Given this list of marker genes AICDA, UNG (uracil DNA glycosylase), POLM, PAXIP1, TNF, TRAF2, APLF, CD86, FCRL3, TLR9, BCL6, TRAF6, IL13RA1, POLB, CD37, IL13, TNFRSF4, PCYT1A, IL2RG, SASH3, PARP3, EXOSC3, IL27RA, NHEJ1, MSH3, MLH1, CCR6, RBP4, TRAF3IP2, IL13RA2, PKN1, CD22, DNAJB9, PRKDC, YY1 (YY1 transcription factor), RIF1, KMT5C (NCBI Gene Id 84787), CD40LG, IL2, HLA-E, PHB1, IL4R, TFRC, ERCC1, CYREN, TBX21, POLL, CR1, NBN, FOXP3, STAT6, PMS2, MSH2, XCL1 (X-C motif chemokine ligand 1), EPHB2, IL6, GPI, TCF3, POLQ, RNF168, SAMHD1, IL4, NFKBIZ, GALNT2, MZB1, BATF, SHLD1, LIG4, SHLD3, RNF8, IL21, BTK, HPX, TREX1, NDFIP1, HMCES, ZPBP2, KMT5B, NSD2, CD40, PTPRC, SANBR, IL5, EXOSC6, MCM3AP, TGFB1, CLCF1, EXO1, CGAS, ATAD5, MSH6 (mutS homolog 6), SLC15A4, SHLD2, XBP1, STX4, TP53BP1, TNFSF4, FCGR2B (Fc gamma receptor IIb), SWAP70, CTNNBL1, VAMP3 (vesicle associated membrane protein 3), IL33, PHB2, HSPD1, XRCC4, TNFSF13, CD28, C17orf99, SUPT6H, TMBIM6, MAD2L2, IL10, here is a description of the gene set: The appearance of immunoglobulin due to biosynthesis or secretion following a cellular stimulus, resulting in an increase in its intracellular or extracellular levels. Human Gene Set: GOBP_IMMUNOGLOBULIN_PRODUCTION studied in species Homo sapiens